Given this list of marker genes SELENOF, NR1H2 (NCBI Gene Id 7376), ZFP90, CNKSR2, POLR1F, PLAAT3, CARF, TCF4, LSM14A, TERF1, SLC30A4, ARL5B, ZNF652, FXYD6, CTSS, ZNF547, USP34, MRPS14, CSTF2, KCTD3, SLC38A1, RAB3B, RBMS3, ATP11C, GPR180 (NCBI Gene Id 160897), NPR3, RPRD1A, XKR4, PLCL1, GGNBP2, IL1RAP, RAB14, CIBAR1, C2orf88, ZFR, RASAL2, ADAM12, ZBTB6, OTULINL, MYRFL, STARD9, SLC29A1, GPHN, C17orf49, POU2F2, LRIG1, SP100, KCTD9, KCNC1, LILRB4, ZNF3, DMRT1, DTWD2, TM9SF2, PAK3, STK26, PDGFRL, ATP13A3, MORF4L2, ANKRD17, TCF12, DIPK1A, AKAP10, MMP24, DNAH5, FBXW10B, CYCS, DISC1, NIPA1, HERPUD2, IFRD2, CACNA2D2, ING3, MTOR, UPF3A, SLC24A2, RELN, RASSF8, CDH17, RAB8B, DKK2, FGB, PPP3CA, RSPH4A, TRMT12, SLC13A1, ZNF419, CREB3L1, ANK3, CCDC191, LEMD3, AHSA2P, PDS5A, SLC15A4, GOLPH3, ZFHX3, KIAA0825, ZNF805 (NCBI Gene Id 390980), ZBTB20, PCTP, GTF3C4, FMO5, DMTF1, MYC, RINT1, NHS, CEP135, MARCHF6, PCDHGC5, ZNF576, WNK3, CDH7 (NCBI Gene Id 1005), ALOX15B (NCBI Gene Id 247), NSRP1, GPC6, NCOA3, ITSN2 (NCBI Gene Id 6454), TNRC6B, BCL11A, CPEB2, COL11A1, AKAP5, TMEM218, CD226, HACL1, ACVR2B, ANKS1A, PCDHGA1, CARNMT1, RC3H2, TCEANC, FMR1, C9orf72, C17orf100, ELF1, TRIQK, LRP3, POU3F2, MOSPD1, MORC3, FABP7, PCDHGA8, CNNM2, ANKRD29, MBNL3, KCNAB1, TMEM161B, TNFSF10, WDR35, ZNF146, POU1F1, ABCB1, HOGA1, PCDHGB7, TSR1, TWIST2, TBL1XR1, UHRF2, PRKG1, PCDHGA2, C11orf87, PLXNA2, A1CF, TMEM196, CRPPA (NCBI Gene Id 730683), KCTD12, OTUD4, BICD2, HYAL4, CDC7, HS3ST5, OSTF1, DPY19L2, U2SURP, CCL20, ZNF160, ICA1, CENPJ, TRPA1, THBD, PCDHGA11, NCOA1, SLC38A6, SLC36A4, RAMAC, TMEM67, CDC14B, DENND6A, TNPO1, PLAA, PCDHGA12, ZNF658, MAPDA, GRIK4, ZNF445, METTL9, SLC1A5, MATCAP2, ERO1B, ONECUT2, ALG13, IKZF3 (IKAROS family zinc finger 3), ANKRD50, FAM169A, GTF2I, ZNF75D, GOLM2, DIP2B, ZNF462, SOSTDC1, CRYBG3, CTNNA3, TEK, ZFX, SSX2IP, PCDHGA9, PCDHGC3, DENND1B, NOX4, CPNE8, GOLT1B, SREK1, CLEC7A (NCBI Gene Id 64581), ARRDC4, TMTC4, PCDHGB3, ASH1L, CCDC180, APOBEC3F, MSANTD2, ZFP28, NSF, HTR7, MEF2C, CLDN16, SLC4A4, MBOAT2, PARP12, ARHGEF12, GUCY1A2, ASB8, DDX60L, NLGN1, RGS13, PLN, PTGS2, HAPLN1, RALGPS2, ELFN1, GTPBP10, GASK1B, SBF2, ASXL2, IGF2R, GRK3, SEZ6L2 (seizure related 6 homolog like 2), SLITRK4, WDR26, TLL2, CTDSPL, PDE1C, RFX3, ZFP36L2, GYPA, ACVRL1, PGM3, TTC28, DOK6, NDEL1, NKAIN2 (sodium/potassium transporting ATPase interacting 2), ATP5F1A, PTPRZ1, YY1, CCN1, SLC30A7, AGO1, TRIM39, SP4, ZNF287, CNOT4, GPLD1, GNA12, COL10A1, PCDHGA7, TJP1 (tight junction protein 1), DEK, FBXO33, B4GALNT3, CDK19, USP15 (ubiquitin specific peptidase 15), SNAPC1, FAM241A, TOB2, MYRIP, ZDHHC21, COL19A1, CD84, NPEPPS, ZNF684, HIPK2, PDLIM5, PKN2, DCLRE1C, BMPR2, MSR1, STON2, MARK1, ZNF485, WWC1, B4GALT1 (beta-1,4-galactosyltransferase 1), LPP, EPHA4, KCNG3, PTPN12, KDR, DOCK2, CACNB4, LANCL2, SYTL5, KLHL5, PCDHGA5, PCDHGA3, P2RY14, PCDHGA10 (NCBI Gene Id 56106), DCUN1D1, TLR4, ETNK1, CREBRF (CREB3 regulatory factor), COX15, ENTPD1, here is a description of the gene set: Genes predicted to be targets of miRBase v22 microRNA hsa-miR-4652-3p in miRDB v6.0 with MirTarget v4 prediction scores > 80 (high confidence targets). Human Gene Set: MIR4652_3P studied in species Homo sapiens from publication Chen Y, Wang X (PMID 31504780)